Given this list of marker genes FUOM, FCSK, SLC35C1, GMDS, FPGT, GFUS, here is a description of the gene set: studied in species Homo sapiens GDP-fucose biosynthesis Human Gene Set: REACTOME_GDP_FUCOSE_BIOSYNTHESIS